The following is a description of a gene set: Erythrocytes take up oxygen and release carbon dioxide Mouse Gene Set: REACTOME_ERYTHROCYTES_TAKE_UP_OXYGEN_AND_RELEASE_CARBON_DIOXIDE studied in species Mus musculus, and this is the list of marker genes: Hba-a1, Car2, Car1, Aqp1, Hbb-bs, Rhag, Slc4a1, Car4, Hbb-bt